The following is a description of a gene set: from publication Tabula Muris Consortium (PMID 32669714) species: Mus musculus Mouse Gene Set: TABULA_MURIS_SENIS_LUNG_CLASSICAL_MONOCYTE_AGEING, and this is the list of marker genes: Srrm1, Psma4, Rps12, Mrpl23, Ran, Uba52, Txn1 (thioredoxin 1), Uqcr11, Rpl13a, Pgls, Micos13, Commd1, Ndufv1, Uqcc2, Ndufb10, Uqcrq (NCBI Gene Id 98240), S100a13, Rps5, Rps8, Rbm25, Ube2l3, Eif5a, Rps3a1, Rrbp1, Srrm2, Pycard, Sys1, Cldn5, Son, Pdap1, Id3, Wbp4, Psmb2, Rps15, Hsp90ab1, Nhp2 (NHP2 ribonucleoprotein), Phf5a, Tbcb, Rpl14 (NCBI Gene Id 67115), Dnajc8, Elob, Slpi, Lgals1, Psmc3, Chmp2a, Metap2, P4hb, Calm3, Sf3b5, Luc7l3, Ncl, Arl6ip1, H2ax, Rps3, Rpl27 (NCBI Gene Id 19942), Ccdc12, Ssna1, Mif, Serbp1, Atp5po, Ap2s1, Eif3a, Csf2rb, Taf10, Psmb3, F10, Lsm4, Mrpl30, Hnrnpab, Ndufb4, Ndufv3, Rnaseh2c, Lamtor1, Rpl41, Hspa5, Gmfg, H2-DMb1, Hsp90b1, AW112010, Prdx1, Idh3g, Mrpl28, Pgd, Rpl8, Atp5if1, Rpl23a, Rtraf, Lamtor5, Rabac1 (Rab acceptor 1 (prenylated)), Cks2, Wfdc17, Csnk2b, Il1b, Ctcf, Smc6, Antkmt, Rsrp1, Cd74, Mdh2, Rps13, Smim11, Tubb5, Rpl12, Ldha, Mrpl18, H2az1, Psenen, Mrpl54, Mrps14, Tuba1b, Ncbp2as2, Etfb, Atp5mc3, Sod1 (NCBI Gene Id 319325), Rp9, Apoe, Rps20, Scgb1a1, Sod2 (NCBI Gene Id 20656), Srsf11, Tmco1, Ifitm1, Anp32e, Rps6, Rpl19, Sdf2l1, Uqcrc1, Arpp19, Rnasek, Smc1a, Ctsd, Rpsa, Edf1, Lgals3, Eef1d (NCBI Gene Id 76576), Rpl21, Tsn, Hp1bp3, Cstb, Ndufb11, Hdlbp, Nucks1 (nuclear casein kinase and cyclin-dependent kinase substrate 1), Pabpn1, Tmed10, Ctsl, Ctla2a, Sec61b, Rps7, Snrpg, Ssr4, Ptma, Rpl22, Gapdh, Ccdc124, Ndufs6 (NCBI Gene Id 407785), Ndufc1, Psma6, Cox5b, Naa38, Lbr, Tmem14c, H2ac23 (H2A clustered histone 23, NCBI Gene Id 665433), Srp9, Mrpl12, Sec11a, Rpl11, Ube2s, Prrc2c (NCBI Gene Id 77858), Ndufa5, Psmd13, Hypk, Hmgb1, Ndufs3, Pgk1, Psmd4 (NCBI Gene Id 19185), Rpl24, Prelid1, Pebp1, Mtch1, Ssr2, Slirp, Ndufb7, Tmem167, Rpl13, Eef1b2, Atp5f1b, Top1, Macroh2a1, S100a10, Rpl32, Ndufa12, Impdh2, Ndufs7, Cox7b, Erh, Snrpd2, Anp32a, Capns1, H2-Aa, Rps23, Tpi1, Ndufb9, Hint1, Jpt1, Rps19, Prtn3, Tax1bp1, Atp5mc1, Ebp, Prpf4b, Apoc2, Vamp8, 2410006H16Rik, Psmb4, Ndufa2, Tmem160, Siva1, Scand1, Ndufb5, Rbm3, Use1, S100a8, Rpl10, Nme1, Fkbp2, Cuedc2, Uqcr10, Rps2, Rpl3, Sh3bgrl3, Dek, Ndufs8, Ifi30, Rpl18a, Calm1, Psma2, Cyba, Tmem234, Cox8a, Hmgb2, Rps27l, Cox4i1, Xist, Emg1, Hnrnpd, Vcf1, Rps9, Atp5pd, Tspo, Hmgn2, Ndufc2, Rps27a, Aqp1, Reep5, Srsf3, Mrpl34, Rnh1, Rps15a, Clic1, Aldoa, Eif3c, Npm1, Mrpl57, Mycbp2, Supt4a, Cox6b1, Rps16, Pold4, Aurkaip1, Smc4, Vcp, Tmem176b, Calm2, Naa10, Ndufa4, Rex1bd, Park7, Rpl36a, Agpat4, Cox5a, Tmem208, Nap1l1, Tmbim4, Gngt2, Atp5pf, Rbm39 (RNA binding motif protein 39), D8Ertd738e, Mrpl20, H2aj, Aimp1 (aminoacyl tRNA synthetase complex-interacting multifunctional protein 1), Rpl6, Tmem176a, Snu13, Psmb5, Swi5, Rpl36al, Snrpe, Hp, H2-Eb1, Mtdh, Atp5mc2, Eif3i, Lsm2, Mrps16 (NCBI Gene Id 66242), Psmb1, Ppia (NCBI Gene Id 268373), Wasf2, Sf3b2, Ndufa8, Ciao2a, Calr, Smdt1, Rps25, Map1lc3b, Eif3k, Ly6a, Trappc6a, Rps14, Fth1, Tln1, Chchd2 (coiled-coil-helix-coiled-coil-helix domain containing 2), Cenpx, Elof1, Banf1, Rps18, Lsm6, Hnrnpu, Ndufb8, Snrpd3, Ddx46, Cox7a2, Mrpl51, Psma7, Sf3b1, Cuta, Eif2s2, Rps11, Nupr1, Snrpd1, H1f4, Rpl15, Micos10, Lsm5, Rplp1, Stmp1, Anp32b, Ssu72, Spcs2, S100a9, Mrps24, Dad1, Tpr, Dynll1, Selenoh, Pfdn6, Atp5mf, Uqcc3, Cox6a1, Mrpl14, Hnrnpa2b1, Atp5f1a, Pdcd5, Gtf2h5, Rpn1, Rpl29, Nedd8, Spcs1, Prdx4, Snrpc, Plec, Nme2, Rpl10a, Grcc10, Llph, Mrps33, Rps26, H2-Ab1, Rps17, Dbi, Rpl35, Rpl28 (ribosomal protein L28), Rps10, Rps4x, Ndufa11, Trem2, Mrpl42, Higd1a, Cyc1, Emp3, Krtcap2, Mdh1, Cope, Prdx2, Hnrnpc (heterogeneous nuclear ribonucleoprotein C), Pkm, Dctn3, H2az2, Vps28, Lamtor4, S100a1, Rpl23, Polr2j, Ndufa13, Rpl27a, Atp5f1d, Tubb4b, Psmb6, Ncf4, Timm13, Zfp36l1, Hsp90aa1, Anapc11, Ndufb6, Bbln, Uqcrh, Ccl5, Trappc1, Eny2, Taf9, Chd4, Rpl18, Bad